Given this list of marker genes SLC29A3, MST1, SEMA4D, IFNGR1, TCF4, GPR35 (NCBI Gene Id 2859), here is a description of the gene set: Histiocytosis An excessive number of histiocytes (tissue macrophages). species: Homo sapiens Human Gene Set: HP_HISTIOCYTOSIS